The following is a description of a gene set: from publication Chen Y, Wang X (PMID 31504780) Human Gene Set: MIR6735_3P Genes predicted to be targets of miRBase v22 microRNA hsa-miR-6735-3p in miRDB v6.0 with MirTarget v4 prediction scores > 80 (high confidence targets). studied in species Homo sapiens, and this is the list of marker genes: BRPF1, TMBIM1, LAMP5 (lysosomal associated membrane protein family member 5), FMNL3, CCDC85C, FAT4, MRPL17, TRAPPC9, RHOBTB1, WDR48, PTPRD, ANKFY1, BRK1, LIN7C, FAM168A, BSN, TMEM123, NEMF, FLRT3, ZBED4, KIRREL1, BZW2, IQSEC2, TMEM184B, KAT2B, ESYT1, FXN, ACOT11, NDC1, COBL, FGF9, ITGB1, ZNF528, USP49, ASF1B